Given this list of marker genes ANG, MOV10, RBFOX1 (NCBI Gene Id 54715), EIF2S1, PABPC3, PABPC1L2A, G3BP1, QKI, ELAVL1, MCRIP2, UBAP2L, CTSG, GIGYF2, RNF135, DHX36, EIF4A1, NANOS3, LARP1, PABPC4, CAPRIN1, DDX19A, DDX6, PABPC1, ENDOV, RC3H2 (ring finger and CCCH-type domains 2), STAU2, YTHDF2, PRKAA2, YTHDF1, HABP4, IGF2BP3, TIA1, CSDE1 (NCBI Gene Id 7812), ZNFX1, LARP4B, RBPMS, DDX3X, RC3H1, KPNB1, DDX25, CELF1, C9orf72, EIF4G1, LARP1B, HNRNPK, RBM4, FMR1, G3BP2, ATXN2L, IGF2BP2, LARP4, ZFAND1, PUM2, CASC3, DYRK3, PQBP1, STAU1, NUFIP2, ROCK1, OGFOD1, ZFP36, LSM14A, TRIM25, FXR1, PRRC2C, EIF3B, PABPC4L, FXR2, TRIM21, PKP1, PABPC1L2B, HIPK2, TIAL1, LIN28A, GRB7, MBNL1, MCRIP1, PABPC5, PUM1, IGF2BP1, SSB, RBPMS2, TARDBP, NXF1, ATXN2, BPI, DDX19B, DAZAP2, RPTOR, PABPC1L, YBX1, YTHDF3, VCP, CIRBP, EIF4E (eukaryotic translation initiation factor 4E), DDX1, here is a description of the gene set: Human Gene Set: GOCC_CYTOPLASMIC_STRESS_GRANULE species: Homo sapiens A dense aggregation in the cytosol composed of proteins and RNAs that appear when the cell is under stress.